The following is a description of a gene set: Human Gene Set: GOBP_REGULATION_OF_NEURON_MIGRATION Any process that modulates the frequency, rate or extent of neuron migration. species: Homo sapiens, and this is the list of marker genes: SCRT1, PLAA, WDR62, PHACTR1, SRGAP2C, PLXNB2, UNC5D, LRIG2, SOCS7, NKX6-1, FLRT2, DRD2, SCRT2, MDK, SHTN1, TBC1D24, NTNG1, KIF20B, CAMK2B, NEXMIF, ARHGEF2, NRG3, COL3A1, DRD1, FLNA, CX3CL1, ADGRG1, TNN, NIPBL, ZNF609, GNRH1, STAT3, RAC1, KIF26A, ULK4, ADAM17, RELN, RNF7, IGSF10, RAPGEF2, GPR173, SOX14, DAB2IP, CAMK2A, CTNNA2, NTNG2, CUL5, ERBB4, SEMA6A, NSMF, UNC5C, SRGAP2, VRK1